Given this list of marker genes PIK3CA, PIK3R1, NRAS, TYROBP, LCP2, PIK3CB, HLA-E (major histocompatibility complex, class I, E), KRAS, FYN, RAC1, HRAS, PLCG1, LAT, PLCG2, SHC1, B2M, KLRC2, GRAP2, BTK, TREM2, SYK, GRB2, PIK3R2, VAV2, VAV3, SOS1, KLRK1, KLRD1, LCK, here is a description of the gene set: studied in species Homo sapiens Reactome Pathway: DAP12 signaling part of: DAP12 interactions In response to receptor ligation, the tyrosine residues in DAP12's immunoreceptor tyrosine-based activation motif (ITAM) are phosphorylated by Src family kinases. These phosphotyrosines form the docking site for the protein tyrosine kinase SYK in myeloid cells and SYK and ZAP70 in NK cells. DAP12-bound SYK autophosphorylates and phosphorylates the scaffolding molecule LAT, recruiting the proximal signaling molecules phosphatidylinositol-3-OH kinase (PI3K), phospholipase-C gamma (PLC-gamma), GADS (GRB2-related adapter downstream of SHC), SLP76 (SH2 domain-containing leukocyte protein of 76 kDa), GRB2:SOS (Growth factor receptor-bound protein 2:Son of sevenless homolog 1) and VAV. All of these intermediate signalling molecules result in the recruitment and activation of kinases AKT, CBL (Casitas B-lineage lymphoma) and ERK (extracellular signal-regulated kinase), and rearrangement of the actin cytoskeleton (actin polymerization) finally leading to cellular activation. PLC-gamma generates the secondary messengers diacylglycerol (DAG) and inositol-1,4,5-trisphosphate (InsP3), leading to activation of protein kinase C (PKC) and calcium mobilization, respectively (Turnbull & Colonna 2007, Klesney-Tait et al. 2006).